The following is a description of a gene set: Any process that modulates the frequency, rate or extent of protein binding. Mouse Gene Set: GOBP_REGULATION_OF_PROTEIN_BINDING species: Mus musculus, and this is the list of marker genes: Bmp2, Tiam1, Atp2a2, Park7, Cdk5, Flot1, Cdon, Mapre3, Aktip, Hfe, Pin1, Wfikkn1, Ttbk2, Myc, Mapre1, Camk1, Lrrk2, Ufl1, Abl1, Hipk2, Dact1, Gtf2f1 (NCBI Gene Id 98053), Mapk8, Tmc8, Sympk, Mmp9, Large1, Ephb6 (NCBI Gene Id 13848), Krit1, Mitd1, Arhgef7, Ep300, Fktn, Usp33, Aurka, Tmbim6, Mark3, Xirp1, Nfatc4, Ldoc1, Efhb, Lrpap1, Plk1, Ip6k2 (inositol hexaphosphate kinase 2), Traf3ip3, Plcl2, Ubash3b (ubiquitin associated and SH3 domain containing, B), Rack1, Cldn5, Carm1, Dhrs7b, Fam220a, Cycs, Adipoq, Wnt5a, Epb41l5, Atp2a3, Dtx3l, Bag2, Ccm2l (cerebral cavernous malformation 2-like), Aplp2, Add2, Shh, Rock1, Tgfbr1, Lox, Abl2, Blk, Spag8, Pcsk9, Nphp3, Golga2, Hopx (NCBI Gene Id 74318), Lrp12, Tex14, Cd2ap, Dab2, Itgb1bp1, Nvl, Psen2, Ifit2, Plxnd1, Gas8, Ttc36, Dkk1, Plscr1, Ctnnbip1, Atr, Septin7, Trib3, Ptprf, Dnajb2, Epb41, Pex14, Ins2, Ran, Tdg, Bmncr, Errfi1, Styx-ps, Mfng, Ppdpf, Tnfsf11, Eif2ak3, Sting1, Lrp1, Rapgef2, Hip1r, Nmd3 (NCBI Gene Id 97112), Styx, Crtac1, Slpi, Rgma, Ldlrap1, Smarcd3, Ticam1, Angpt1, Tert, Dscam, Grem2, Spta1, Cblb, Ralb, Cdc42, Frmd7, Vtn, Usp9x, Hdac4, Ddx11, Tcf7l2, Tfip11, Il10, Phlda2, Cdkn1a, Pdgfb, Src, Bdnf, Tmem132a, Aurkb, Cthrc1, Cdkn2a, Zfpm1, Ide (NCBI Gene Id 73765), Stub1, Rfng, Hdac5, Trim21, Mapk3, Nes, Agrn, B2m, Nog, Lfng, Mdga1, Spon1, Itga4, Adam15 (ADAM metallopeptidase domain 15), Tle5, Rpl11, Anxa2, Wfikkn2, Akt1, Pin1rt1 (NCBI Gene Id 241593), Plcl1, Gsk3b, Dzip1, Snapin, Ripk2, Kdm1a, Dtnbp1, Ttbk1, Gnl3l, Psme3ip1, Pcbd1, Dnaaf11, Bambi, Bmp4, Ckmt1, Add1, Mcrip1, App, Prkn, Psen1, Pim2, Bax, Cp, Cyld, Pabpn1l